Given this list of marker genes CHST15, SLC12A1, NBPF11, ID2, ARHGEF10L, CBLL1-AS1, MAPKAPK3, MTUS1-DT, NOL9, DHX36, ALKBH2, SNRPB, LYPLAL1, GATAD2A, KMT2C, IKZF3, RFPL1S, FADS1, CD274, NCK1, CTSD, GAB1, TMEM69, MT1E, TMEM144, BOD1L1, MIR584, FRG1HP, HHATL, RHOT1, NFE2L2, PKM, SMARCD2, ICE1, AGT, ZNF503, TEAD4, MPLKIP, LINC02983, IP6K2, PPM1N, PDPR, HAGH, SRFBP1, GABRE, PIK3R1, FAM107B, FLVCR1, LINC02960, ANKRD1, PSORS1C1, CUX1, CNNM3, MBTPS2, CLDN23, HNRNPL, LRPAP1, LBP, RABGAP1L, KDSR, LNCATV, SVOP, MSANTD2, GTF2H2C, IKZF4, STX10, MOB4, MTCO3P47, CATSPERB (NCBI Gene Id 79820), KLF16, DLST, MOV10L1, CCDC107, ZRANB3, TMEM256, CDC16, LIMD1-AS1, KCNK12, DGAT2, CHKA-DT, PLEC, IZUMO4, HTR1A, MAPK11, RRN3, CHIT1 (chitinase 1), INTS5, MKRN1, MEF2A, RBP4, FGG, ADCK2, PPFIA3, MAPK8, LDLRAD4, ENSG00000238185, DRAIC, FBXL8, AARS2, SNORD54, DNAAF4, MAN2C1, COPA, NKIRAS1, SYT7, MAP3K3, R3HDM2, EFCAB13-DT, AGPS, NFKBIA, ASAP1, MBNL3, SH3TC2-DT, SCN4A, INKA2, GTF2IRD1, CAPRIN2, TCIRG1, PHF21A, ZNF451, LINC01976, HOXA4, ENSG00000229425, KRT8, PSMA3-AS1, TARS2, DHX8, C3orf38, ZNF629, MSH2, MRPS15, SLC2A4RG, POLR2J, AP2A2, PDLIM1, EFHD1, MRAS, NECTIN3-AS1, AMACR, MAPK8IP2, OGT, AQP10, CTSC, MMD, MRPL13, RHEX, DZIP1, ZNF491, WIZ, CAPN10-DT, HNRNPD-DT, MNAT1, MIX23, PSEN1, SEPTIN11, DPP9 (dipeptidyl peptidase 9), NUDT3, RNU7-27P, BHLHE40, CELSR3, ZC3H7A, CD22, NKAPP1, TLE4, ARRDC3, LINC01977, DUSP9, JSRP1, SRRM3, DPY30, DNAAF4-CCPG1, SLC51B, STMN3, MOSPD2, DNAH14, ADH4, PRR4, BICDL3P, SMG1P1, RAD51C, SLC16A3, RNU4-1, YAP1, GET1, TRIM69, UBE2Z, LITATS1, TLE3, LINC02593, PGGT1B, ERICH2-DT, ZNF420, STX18, FAM86C2P, CHKA, EEF1A1, LINC02275, RN7SKP175, ZBTB40, FANCG, SYNJ2BP, HNRNPA1P30, IRF2BPL, ABHD8, NELFCD, TP73-AS3, WDR11-DT, SEMA3B, RNU6-8, TLR3, TXNDC11, EIF2D, GPS1, HIBCH, SUB1, ENSG00000251095, HDX, PCID2, ZNF580, EFNA1, METTL25, SNORD3J, BZW1-AS1, SQOR, EIF1AD, ARID4A, MYO18A, LINC02324, ITGB5, MTBP, ZNF391, GAS8, ZNF827, ENSG00000260288 (novel transcript), TACO1, ATG2A, GIPC1, COL18A1-AS2, DTX4, NOS3, SIRT1, SNORD118, MTERF1, ABCA3, RCN1, GRSF1, HAAO, ZC3H12A, RNVU1-30, UBE2D3, NCBP3, PPARGC1A, NAB1, BCKDK (branched chain keto acid dehydrogenase kinase), ACCSLP1, RPL35AP2, RNU6-599P, ATAD2, GCFC2 (NCBI Gene Id 6936), CCL20, GPBP1L1, SERPINA12, SLC44A1, VIRMA, ROCK1P1, PRAG1, INAVA, RASAL2-AS1, TMEM220, M6PR, MIR4519, HNRNPR, F2RL1, DBF4B, SENP1, IPO7, ECH1, DLC1, CACNB4, IDH3A (NCBI Gene Id 3419), SEC24A, OBSL1, MFSD8, LINC01749, NOC3L, ZC3H7B, STKLD1, IER5L, SLC5A6, MANSC1, RBM18, SORBS3, CDR2, ATP7B, FAH, KRT19, CERS2, IGF2BP2, PCAT14, CYRIB, ZNF554, C1RL, GSTO1, LINC02919, ZNF767P, THOC5, CHN2, ERCC2, RPS6KL1, NHERF2, DST, SSTR5, PFN2, LRIG3, GEMIN5, SGK3, UBE2V1P4 (UBE2V1 pseudogene 4), CENPU, ZNF416, MAST3-AS1, SPA17, NR1I3 (NCBI Gene Id 9970), NBAS, C5, DRAP1, SH3YL1, ZNF281, RPS23, MAVS, GRINA, OSBPL10, SUGCT, RANBP3, USP54, CHMP1B (charged multivesicular body protein 1B), RAP2A, HS2ST1, LSAMP, COMMD2, ZMYND11, RSPH3, FOXN3-AS1, SELENOP, CBX8, IFT56, SERPINA11, HSD17B11, USP13 (NCBI Gene Id 8975), ATF7IP2, BRWD1, NDUFS7, RAD52, SCAMP1-AS1, NECTIN3, GEMIN6, IER3-AS1, MCPH1-DT, OTUD7B, NDUFS3, SPRED2, CAPN10, ZNF20, NOMO3, SERPINF1, SH3GL1, ZC3H3, EZR, TRIM67, VGF, JADE1, COMMD6, JRK, NSG2 (NCBI Gene Id 51617), KCTD5, TRMU, TMEM14B, RPL31P24, GGPS1, WHAMMP3, UBE2L3, ZKSCAN8P1, RALGAPB, PELP1-DT, LINC02410, CA3-AS1, ARMT1, CD63-AS1, MYCBP2, KCNC1, ENSG00000212182, TMEM242-DT, CCNI, RRAGA, G6PC3, COPS7A, IER3 (NCBI Gene Id 91950), TM9SF4, TMEM231P1, CPD, MIR17HG, STXBP5L, LINC00957, NUDC, ARL5B, TENT5B, CFL1, HMGA1, TEX2, NDRG2, CAMKK2, ALPL, EPB41L5, SOWAHC, ABCA4 (NCBI Gene Id 7815), PRXL2A, CRYBG1 (crystallin beta-gamma domain containing 1), RPH3AL, TAF15, LINC01767, PTEN, ARSB, ZNF286A-TBC1D26, CTNND1, TAF4, DDA1, CRIM1-DT, MTF2, VTRNA1-1, CA5A, HPN, EVL, LPCAT3, ASB1, FANCB, TFB2M, DNAJC2, GPR158, ATG16L1, LMNB1, ZBTB18, LINC02458, VRK3, METAP1D, TBC1D19, PTPRN, P2RX6, SRSF11, LINC02166, SEPTIN9, PGLS-DT, MFAP1, ZC3HAV1, TMEM242, CWF19L2, DUSP6, PLEKHM3, ZMIZ1-AS1, PDK4-AS1, MACF1, ENSG00000293341, ZNF581, EIF3F, TDRKH, BHLHA15, CLIC4, TMTC2, TVP23B (trans-golgi network vesicle protein 23 homolog B), FAM227B, FOXC1, LINC02418, ALKBH3, CHCT1, RGS5, FIRRM, CENPN-AS1, MRPS14, SLC7A6, ADRA1A, APBA3, NBPF12, BTNL12P (butyrophilin like 12, pseudogene), F2, EHHADH, NDUFAF1, MASP1, RANBP3-DT, TBL1X, EPM2A-DT, RMDN2 (NCBI Gene Id 151393), SLC45A4, LMO7, TLL2, ESRRA, NDUFAF5, SIKE1, MIR145 (NCBI Gene Id 406937), EDC4, SERPINB9P1, TRIP4, EEF1AKMT2, SSBP1 (single stranded DNA binding protein 1), NDUFA8, SPRY2, SMG1P3, COX16, WDFY1, ARID4B, SLC9A8, MTHFS, HEG1, UGGT1, ORMDL3, RGS3, SEC14L5, RXRB, EBPL, STAT1, ZCCHC2, COL27A1, RNVU1-28, SSUH2, KPNB1, MAML3, UBB (ubiquitin B), CCDC106, ASXL1, ZNF821, WDR13, CENPF, SH3D21, PLK1, FAM118B, CITED2, B3GALT9, GRIA2, CPT2, DSTN, EIF4H, CAPZA2, POM121C, AGO2, TMEM243, HDAC2, PNPT1, FBXL18, MTERF4, CNTRL, GLRA1, DDX11L5, CPPED1, TVP23C-CDRT4, ZER1, UBR5, RNVU1-19, PRKAB2, INKA1, ENSG00000187951, EMC3-AS1, HINT2, B4GALT4, CUL3, ZMYND8, CASD1, TSC1, GRM1, EEF1A1P23, HERPUD2-AS1 (NCBI Gene Id 101930085), UBAP1L, ZNF100, DCTPP1, DDX51, MRPS31P5, EBF4, ATRAID, RREB1, SNORC, ARHGEF2-AS1, TBC1D8, LINC00240, LINC01186, SGMS1, MIR3928, CNBP, MAML2, BMF, CDC37L1-DT, RAD9B, ALG8, LINC01273 (NCBI Gene Id 101927541), BORCS8 (BLOC-1 related complex subunit 8), RPL22L1, VLDLR, FRS3, HNMT, MIR22HG, MYH14, ZSCAN16-AS1, LIX1L, ANXA4, DHX40, C11orf65, OAZ1, FBXO36P1, KRTAP3-1, RRP15, LINC02980, ZNF131, POR, TCAF1, RNFT2 (ring finger protein, transmembrane 2), ABCD3 (NCBI Gene Id 5825), CENPL, TTI2, SRP72P2, CSTPP1, F10, ODC1-DT, NCOR1, TMEM44, MIR7-3, ALDOA, RGS14, CMBL, UQCC6, PRND, CNPY2, FBXO30, IFT122, TCF12, ATP1B1, AKR1C1, ZNF205, DTD2, PLA2G4E-AS1 (NCBI Gene Id 101928388), RO60, LHFPL5, PRKCA-AS1, HDAC5, SELENOF, LINC02585, NBPF25P, SPCS1, RPL37, CELSR1, STXBP6, TGFBI, WDR25, RIT1, AHSG, FA2H, RBSN, EIF4E2, MIR762HG, RCOR3, ZNF252P, CSNK1A1, NIT2, AJUBA-DT, RCAN1, NCSTN, TNFRSF21, CACNG2, RNU11, NUP54, SCGN, UGDH-AS1, ZNF786, SSTR5-AS1, INTS10, BCL6, MTHFD1L (methylenetetrahydrofolate dehydrogenase (NADP+ dependent) 1 like), PDCD6, WDR31, ALG10B, OSBPL6, RMND1, LOX, COMMD4, MSTO2P, FLOT1, CKAP2-DT, XRN1, ZNF41, ELL, MICU3, SAR1A, MYL5, SMAD3-AS1, ACVR1, ZNF860, WARS1, MIR4437, ENSG00000268129, TMEM250, LINC01586, AKAIN1, AADACP1, CISD2, ARID1A, GOT1-DT, ST6GALNAC6, ENSG00000235020, MHENCR, MED4, LINC02976 (NCBI Gene Id 123706548), MARCHF4, TAF1B, ARL6IP5, ZNF846, ST6GAL1, ZC3H6, SACM1L, EPOR, GIT1, CCDC57, TMEM98, GSX1, PAQR7, STAG3L5P, FARSA, TBC1D22A, GLTC1, C19orf25, FRG1, DGCR8, RBFOX2, ZNF790, ELDR, TBPL1, CGGBP1, CRLS1, SNHG11, NGEF, IER2, FGA, ZNF213-AS1, MTUS1, E2F5-DT, ATXN2L, IRS1, RPS7, ACSL5, TFRC (transferrin receptor), STN1, RPH3AL-AS2, MAGOH-DT, MRPL46, CNTNAP3P2, SDAD1, KLLN, CDC27, VARS2, AFDN, HADHB, ATP6V1G2, C8orf82, SNRNP27, UICLM (NCBI Gene Id 200772), ABCB10, RNU6ATAC, RAD51-AS1 (NCBI Gene Id 90408), UBE2I, NCOA7, TACC3, IMPA2, SLC35D1, MIR1538, ZBED5-AS1, ENSG00000224090, FLVCR1-DT, ACP2, FAM21FP, RNF185, CYP7A1, SYNCRIP, DOCK4, AK2, BPHL, UFL1, EXD3, ACBD4, XPOTP1, P3H2-AS1, NSL1, TMEM68, RRBP1, RPL41, MLYCD, CKAP5, KHDRBS1, GNAL, APOA1, FOXN2, FBXO6, ZNHIT6, SCTR-AS1, CAHM, NUS1, FAM133B, ADNP, LASP1, NCOA2, VPS37D, KCTD18, CTCF, CDC37L1, IL4R, TSGA10, WNK4, CCDC59, PCDHGB1, TOB1-AS1, TMEM129, MEAF6, LTO1, NSA2, TRGV7, RNVU1-6, RPL15, MIR5588, SRI, PUS10, UNKL (NCBI Gene Id 65259), CUL4A, RPL39P40, CCNP, CTXN2, TRPC7, GMEB2, EIF1, POGLUT1, SLC25A11, CABLES1, TRABD2A, DCBLD2, TOMM22-DT (TOMM22 divergent transcript), DECR2 (NCBI Gene Id 57382), LINC01719, TRIP12, DIAPH1, SLC33A1, GLIS2-AS1, NET1, NFKBIZ, CASZ1, ENSG00000257346, ZNF217, FOXN3, GTF2B (NCBI Gene Id 2959), TRIM35, CRYBB2P1, SLC25A25, TSEN54, NCOR2, SEC23A, UBA3, SLC9A5, ZNF600, JAGN1 (jagunal homolog 1), DNM1L, DNAJC19, AURKAIP1, NXN, UBP1, SLC38A6, ELAC1, BTG2-DT, ADD3, ECSIT, NFATC3, FAM186A, KMT5A, COPB1, OSMR-DT (NCBI Gene Id 101926904), HNF1A-AS1, QTRT2, MXI1, MCM8-AS1 (NCBI Gene Id 101929225), N4BP2L1, TTYH1, FUT5, PAQR4, TRAPPC6B, MRPL30, EFTUD2, DHRS7B (dehydrogenase/reductase 7B), PLCL1, RBM45, ENSG00000270571, MIR300, ADGRB3, ARHGAP18, CDH23, KATNA1, PTPN18, UTP11 (NCBI Gene Id 51118), MTIF3, SNX12, ASGR2, ZNF277, CTDSP1, PLXDC1, CISH, RANBP9, CMC1, TMEM14B-DT (NCBI Gene Id 118597831), SMG1, ZBED6, FOSL2, ZNF503-AS2, ADAT2, PFKM, CCT6P3, CORO6, AQR, IL6R, TPST1, LMCD1-AS1, TTLL1, CYB5R4, ZNF280D, ERICD (E2F1-regulated inhibitor of cell death), NRP1, RPS19 (ribosomal protein S19), NEAT1, UGT2A3, ZNF30-AS1, H2AC17, SUPT7L, VWC2L, CARNMT1-AS1, GTF3C3, TIMM23B, TATDN3, RAB10, RILP, PEX3, INHBE, HMGXB3, FRG1-DT, SNX10, LMNB1-DT, GFI1B, FABP5P3, VPS25, PC, NUDT8, SORD2P, GRB7, SLC13A5, RNA5SP60, SHTN1, TRIM44, FANCC, CPLX2, CCT6A, SSBP4, ANKRD54, SKIDA1, ZNF350, KIAA1217, SPAST, TAF5, RESP18, ZNF706, LONRF3, DNMT3A, SH3BGRL2, TAS2R14, FER1L4, SLC34A3, SLC39A3, PRH1, ZBTB34, CATSPERD, DR1 (down-regulator of transcription 1), ACYP2, CHD6, GPR89A, UCHL5, ZNF747-DT, CCS, HRH3, FGGY, ALDH1B1, CERNA3, EXOSC3, COPS4, LINC03064 (NCBI Gene Id 105371264), CDK5RAP1, PPM1H, RPL4P6, CDKN2AIPNL, EEPD1, EDF1, GPT, PDCD6P1, POLR2C, SOS1, ZNF337-AS1, SMAD7, EBLN3P, PRR3P1, CACNG2-DT, MYADM, MIR7973-1 (NCBI Gene Id 102466250), PARG, MPP1, POLG-DT, TAF1 (TATA-box binding protein associated factor 1), MRPS23, VIRMA-DT, LINC01900, SCAF11, HPX, ADRM1, FAM86C1P, NME9, DOP1B, CRADD, TUBGCP3, SPHK1, DTWD1, RNGTT, PSMF1, BLTP2, RBBP6, GAMT, PAFAH1B1, TINAGL1 (tubulointerstitial nephritis antigen like 1), VPS29, POGZ, HNRNPLL, PGLS, USP37, SNHG6, DCUN1D4, MOB3A, COG1, PSMD8, SNX30-DT, C10orf143, FIZ1, ZNF473, RNF130 (NCBI Gene Id 55819), TMED9, TMEM179B, E2F6, METTL9, ENSG00000213963, PSMC2, SRARP, IMPA1, SHFL, KCTD21-AS1, TBC1D16, ZFAND2B, CLDN6, GTF3C5, PSME3, TMEM39A, PARP10, ZBTB45, ALAS1, SNX7, WWP2, EEFSEC, CYP3A43, YARS1, DGUOK, SENP2, WDFY2, YPEL3-DT, AHI1-DT, POLDIP3, RUSF1, PRKCZ, GUSBP18, ABCC2, ING1, SFI1, KPNA3, RASA4CP, HPD, ATF3, CEACAM16-AS1, CCDC192, AFG3L2, CEP112, LINC03037, FNDC3A, DAB1, C3, VIP, CCN2, FBXW2, POLR2J4, ATF7IP, NACA4P, SLC38A9, FCHSD2, AMOTL2, LINC00485, CCDC103, MED23, RNVU1-31, ANKRD46, HTR5A, TTC3, DCTN6-DT, ISLR2 (immunoglobulin superfamily containing leucine rich repeat 2), BRF2, CCDC159, SLC7A5P2, APMAP, LARP1, RNF167, NUBP1, C12orf76, ZFYVE27, PLS1, SOCS4, NR1D1, TUBGCP6, CENPT, HMGB1P8, SMAP2, DYRK4, TTC27, TF, AP3B2, FBXO38, SPRING1, STT3A, BCKDHB, BBOX1, TNFSF4, TOP3B, FBXL17, TMEM268, LIG4, AKAP8L, SLC2A6, HCG15, PPIH, ARL14EP, COMMD5, SIAE, ANKZF1, MARCHF8, FOXA2, DISC1, BARHL1, NEK9, CDIP1, RPL9P14, SLC25A18, POM121 (POM121 transmembrane nucleoporin), POLG, FARP2, SLC25A36, OSGEPL1, SLC25A10, GPR39, STAT4, KIFC3, IVD, ARHGEF1, MIR375, NR1H3, ACTR6, GPATCH4, LINC02447, FAM3B, CYB5AP2, SPATS2, H2BC17, GFM2, FBXO34-AS1, ZKSCAN3, MBD6, BECN1, RGMB, GSR, ENSG00000232995, LNCRNA-IUR, USP2, RAB11A, COLEC11, NCOA3, TIGD2, RERE, TIA1, PRDX1, FOXJ3, DOK6, ZNF444P1, N4BP1, SERPINA1, SLC25A19, SEPTIN12, TBX2-AS1, SERP1, KNG1, TCEA1, SLC25A45, PTK2B, INKA2-AS1, MRPL16, SUN2, SCP2, JPX, MITD1, ARHGEF39, SRP19, SAXO1, ACKR2, ID2-AS1, HBP1, CKAP2, NME1, SLC24A1, ELOVL1, MAP3K5, NFAT5, LRMDA, MORN5 (MORN repeat containing 5), PRSS27, CNOT9, NSFL1C (NCBI Gene Id 55968), WEE2-AS1, RCOR1, TDRKH-AS1, MOGAT3, CAPS2, SULF2, SNTG1, MIR5091, GREB1, POLR1A, RFXANK, EOGT-DT, SLC5A2, CNGA1, CAP2 (NCBI Gene Id 10486), NUF2, SPOP, FRS2, ZBTB20, FAM13A, ARHGEF2, GPX2, DNAJB11, ODC1, DTNBP1, HADHA, ACSM3, MRPS31, NDUFA11, BABAM1, SOX2-OT, HERPUD2, ATMIN, SCAMP1, USP47, LINC01484, DMAP1, KIF16B, MIR549A, RCAN3, MPC2 (mitochondrial pyruvate carrier 2), IRF2, RGMB-AS1, TOR1A, MAPK8IP1, GRB2, ENSG00000271860, CTCF-DT, MDH1 (malate dehydrogenase 1), ZNF354B, ENOSF1, DENND5B-AS1, RNF19B, HID1, PGRMC2, LINC00870, PIM1, AUTS2, UGDH, RTTN, FRA10AC1 (NCBI Gene Id 57208), SNAPC2, ADPRS, SCAND3, LPAR6, KIAA1586, OTULIN-DT, APOA2, APOC3, RNU5E-1, CTNNB1, NLGN2, GPRC5C, DDX23, TTLL4, MBNL1, LGR5, RHOB, LINC01703, ONECUT2, PELP1, ACOT13, TPH2, SCG3, ERCC3, SMG6, CHI3L2, GNPNAT1, ZFP1, RRP7A, ZBED4, ZEB1-AS1, PCBP2, PSPH, MAB21L3, TGFBR3, RBBP4, PAFAH2, AOC4P, PTPRS, MRPS10, PEBP1, NUP107-DT, EMC3, KLHL17, SH3BP2, ARIH1, ANKRD11, LINC01820, NSUN6, IGF1R, CRIM1, GRIN1, ARID2, LONP1, NUP107, TFF1, LINC01600, MED15P9, METTL15, MELK, NIPAL1, TYMSOS, GLTPD2, TUBB4B, MSANTD2-AS1, METTL18, TDRD7, WHAMM, MRPL38 (NCBI Gene Id 64978), KPNA7, LMBR1, ERAP1, DOT1L, CIB2, FBXO36, ZFHX2, LINC02280, RNF8, CALM1 (calmodulin 1), TRNAU1AP, FAM228B, BCAR1, SH3KBP1, ZEB1, MOB1A, SNX31, RGN (NCBI Gene Id 9104), OPA1, TARBP1, ZNF286A, DRAM1, UPP2, KDM3A, BLTP3B-DT, DHRS3, NFKBIL1, PWWP2A, ZNF641, TRIM25, ABCG2, CASKIN2, MEIS1, RPS29P16, SFXN5, MRRF, UFL1-AS1, IRF2-DT, KBTBD4, NORAD, LAPTM4A, GTF3C6, SOWAHB, CAPG, NRIP1, ZDHHC18, SYN3, ZNF23, TNRC6B, VTRNA1-2, OMA1, CSNK1D, FNDC3B, CDK14, MAPK1IP1L, REXO4, DNAAF3, ZMIZ1, SH3TC2 (NCBI Gene Id 79628), ZFP30, YPEL3, NUFIP2, NRSN2, RAB3D, QKI, TLCD3B, MIR9-3HG, CRIPTO, ARRDC3-AS1, PRRT1B, ERLIN2, CIRBP, GRM2, FLNA, NELFA, CCZ1B, LINC01843, USP32, ANKRD40, LRRC58, SMC5, LYPLAL1-DT, DGKD, UBXN6, ZKSCAN2, ARHGAP24, DRD3, ATP13A4, PPIA, ADAM22, VLDLR-AS1, YTHDF2, LINC01560, TEX14, SAMD1 (sterile alpha motif domain containing 1), SLC43A2, RPUSD4, MIR3913-1, ATXN7L1, NME1-NME2, FAHD1, SECISBP2L, UCP2, LINC01270, PGBD5 (piggyBac transposable element derived 5), CTSA, PPP1R3C, TAB1, TOMM20L-DT, ETV6, AP4B1, TTC21B, COQ5, ENSG00000267882 (novel transcript, antisense to ZMYND8), FZD1, BTG2, SCAMP5 (secretory carrier membrane protein 5), RNF111, POLM, CYREN, PTPA, OLA1, SLC7A7, PER2, SNRPB2, ACSL6, SRRM2, RAB37, SMC3, RASAL2, DRG2, ZKSCAN4, MED15, EVA1A-AS, PTP4A2, TRIM26, RBMS1, P3H2, SLC16A5, PPP1R9A, PPP2R5B, CDH24, IFFO1, NKPD1, DPY19L1, ZFYVE16, MRPL44, PLCB1, EEIG1, PGP, TMEM179, PPCDC, LONP2, WDR11, MAPKBP1, FRG1DP, ZNF266, PLAAT5, RAD9A, USP1, FRG1CP, RPS19BP1, WAC-AS1, AZGP1, RNY4P10, ATP5ME, DCTN5, OGDHL, GSTCD, MAGOH, EXOC2, SDC1, RAB31, RBM17, SYP, C11orf68, ISL2, ST18, ZNF490, ZNF282, BFSP1, ATP5MC2, PSCA, KRR1, SRSF6, MRPL54, TOB1, ANKEF1, DNAI1, H3C12, GOT1, TSPAN19, SEZ6, AADAT, DARS2, ATG9A, KDM1A, SLC9A1, RCL1, EPB41L4B, RBM28, STEAP1, MRPL39, ZBED5, MAP2K6, DCAF11, STX18-AS1, FAM169A, PLG, TOB2, TOMM22, C2orf15, DSTYK, RAD51, HIVEP1, PCAT6, ZBED9-AS1, UBR3, LAPTM4A-DT, DNAH2, HNF1A, MICU2, DAPK2, PRKD2, DPY19L4, DBNDD1, ANAPC5, TMEM181 (transmembrane protein 181), GNAQ, LINC02428, ABCA17P, SYNJ2BP-COX16, POGK, PRPSAP2, STAG3L5P-PVRIG2P-PILRB, CTXN2-AS1, GSPT1, SLC4A1AP, HMGN2P46, CYP26B1, INTS12, ABT1, ARHGAP11B-DT, AMBP, CD63, SHB, OBSCN-AS1, LINC00216 (NCBI Gene Id 55451), CALM2, OSMR, FLRT3 (fibronectin leucine rich transmembrane protein 3), BIRC2 (baculoviral IAP repeat containing 2), ZNF524, RPL27, C2CD5, PIK3R2, TASOR2, RNF208, MRPL48, MBD4, NAPG, MDM2, FBXO34, SCUBE1, ADAR, BZW1, C2orf42, ACTL6B, ZFPL1, NOC4L, EFCAB13 (NCBI Gene Id 124989), NR2F1, SMG8, RHOT2, NXF1, NDUFS8, ZSCAN2, ZNF770, WASHC2C, B4GALT2, LUC7L, ZSCAN12, METAP2, EOGT, APOB, CCDC18-AS1, FBXO38-DT, CDC42BPB, ILVBL, PGC, PDK4, ABHD18, LINC02352, CCNG2, ATP6V1G2-DDX39B, ISG20, PPP6R1, NACA, ACTR3, TPRA1, PDE4C, EXOC3L4, ADRA1D, SSX2IP, ZC3H11A, SLC2A9, GPR6, ARSF, SNAP25-AS1, HS3ST2, TYMS, SIX5, HEMK1, APLP2, TAS1R1, SART1, CRBN, TRAPPC9, CISD1, TEX10, PRR5, IKBKG, MVB12B, NOXA1, ZCCHC4, PDE6D, VMAC, NPDC1, INSR, MIR6781, SLC25A40, AHI1 (Abelson helper integration site 1), RAB27A (RAB27A, member RAS oncogene family), SSU72-AS1, FILIP1L, H3C6, SRSF7, ANXA2, NKAIN1, KCNQ2, MGRN1, HSD17B12, CCDC88A, CFAP20, COPS7B, CDCA5, SATB2, SETD5, TRIB3, HNRNPD, EP400P1, CBLL1, CCDC191, MBL2, RTF2, WDR24, CPNE8, DSP-AS1, SNORD3A, PHACTR4, RBBP5, SNX30, TBCCD1, TMEM177, EFL1, ZBTB8OS, CBX4, ZSCAN9, SLC2A3, ALDH3A2, N6AMT1, PEX5L, CCNC, R3HDM2-DT, VPS51, AJUBA, MTIF2, SHC2, PLEKHO1, ELF1, RMND5A, TSG101, SERPINB6, MIXL1, TMEM256-PLSCR3, SLC35A3, MAD2L1BP, ITFG2-AS1, CLOCK, LFNG, TBC1D13, WAC (NCBI Gene Id 55468), SEC22B, SF3B6, EIF2S2P5, SNORA74C-1, KEAP1, BATF2, EPM2A, RRAS, LMCD1 (NCBI Gene Id 29995), RN7SKP92, WDR36, GUSBP1, FAM98B, DCLRE1B, RPS7P1, RBPJ, CDC14B, FSD1L, TRADD, LEMD3, C5orf63, HS3ST3B1, ENSG00000282793, TRIB1, KPNB1-DT, SCAT1, TGIF1, CRK, RBM23, SZRD1, ZCCHC7 (NCBI Gene Id 84186), BORCS8-MEF2B, GCNT2, STX16, ABHD12, PLEKHG2, PKDCC, LRIG3-DT, KCNH6, POU2AF1, CAMTA2, AFP, POLR3B, RNU6-323P, RPS20, ARHGEF37, LRRIQ1, SEMA4C, SCAF1, SCG2, TOMM20L, CTH, GUSBP2, LRP12, HCG14, TRIM2, FBXO21, UBA5, VKORC1, U2SURP, ZNF12, MICB, GABBR2, SLC1A4, SNX8, HNRNPUL1, NCK1-DT, CCT2, JPT2, PTCD3, EHD4, IQGAP2, SARM1, BRD1, CCND3, SCRT1, TIGD1, HCG27, TGS1, SLBP, ITGAL, MIR3678, CPB2, TMEM202-AS1, SGMS1-AS1, DENND10, NHSL1, CDK11A, NEURL2, PSD4, CDAN1, TDP2, ENSG00000199566, MIR7-3HG, NPPB, OSBP2, USP12, DCTN6, NEDD4, ETV4, DYNC2LI1, TBX3, GCHFR, POTEF, SMIM13, UTRN, DSP, NOP10, DAGLB, BANF1 (barrier to autointegration nuclear assembly factor 1, NCBI Gene Id 8815), LINC01588, SERPINA3, FBLN1, GRAMD4, SEPTIN10, ERCC1, CLNS1A, CNIH2, KLRG1, GRN, FAM187A, PACSIN2 (NCBI Gene Id 150377), CA2, PIAS4, WSB2, ZBTB38, SLC13A3, PDGFRB (NCBI Gene Id 5159), CNST, ARHGEF12, SGO2, TNPO1, RANBP6, EIF2B3, INTS14, DNER, S100PBP, TMEM255A, PCSK1, HISLA, KANSL3, BCO2, IST1, DCP1B, NMBR, RFNG, TMEM205, SSU72, MTRF1, LRRC40, RUSF1-DT, FGD4, RWDD1, TFDP1, DNAJB1P1, LINC01124, MAZ, NUTM1, LINC02015 (long intergenic non-protein coding RNA 2015), SNORD13, ENPP3, CAMSAP2, WDHD1, VSNL1, BRCA1 (BRCA1 DNA repair associated), CHP1, HES1, ZNF74, BCL7C, INHA, ANKRD20A5P, ATF6, HMGCR, ADPRHL1, GNE, AKR1A1, PALB2, STX16-NPEPL1, SP5, ANKRD34C-AS1, CDC42P1, STAT3 (signal transducer and activator of transcription 3), HDAC2-AS2, ECHDC2, SYN1, CENPA, SNX24, DUS1L, FRG1BP, ZNF815P, SEC13, VSIG10, SPATA13, RAP1GAP, DOHH, TVP23C, EXOSC6, OPRM1, LMAN2, UNC80, APOA5, PCLAF, NAGLU, HAL, here is a description of the gene set: species: Homo sapiens Genes containing one or more binding sites for (HMG20B) in their promoter regions (TSS -1000,+100 bp) as identified by GTRD version 20.06 ChIP-seq harmonization. Human Gene Set: HMG20B_TARGET_GENES from publication Yevshin I, Sharipov R, Kolmykov S, Kondrakhin Y, Kolpakov F (PMID 30445619)